The following is a description of a gene set: from publication Sansom OJ, Reed KR, Hayes AJ, Ireland H, Brinkmann H, Newton IP, Batlle E, Simon-Assmann P, Clevers H, Nathke IS, Clarke AR, Winton DJ (PMID 15198980) Although Apc is well characterized as a tumor-suppressor gene in the intestine, the precise mechanism of this suppression remains to be defined. Using a novel inducible Ahcre transgenic line in conjunction with a loxP-flanked Apc allele we, show that loss of Apc acutely activates Wnt signaling through the nuclear accumulation of beta-catenin. Coincidentally, it perturbs differentiation, migration, proliferation, and apoptosis, such that Apc-deficient cells maintain a crypt progenitor-like phenotype. Critically, for the first time we confirm a series of Wnt target molecules in an in vivo setting and also identify a series of new candidate targets within the same setting. studied in species Mus musculus Top genes up-regulated at day 5 of Cre-Lox induced APC knockout in the intestine. Mouse Gene Set: SANSOM_APC_TARGETS_UP, and this is the list of marker genes: Uri1, Aqp4, Zc3h8, Tnfrsf12a, Vmn1r42, Ephb3, Krt23, Trpc2, Hnrnpa1, Hunk, Zfp746, Cdca7, Nr2e3 (nuclear receptor subfamily 2, group E, member 3), Paics, Sgf29, Tlr7, Tmem131l, Msx1, Golga3 (golgin A3), Tubb2b, Hs3st1, Ang, Foxa3, Bcas2, Ung, Ets2, Ube2t, Tcof1, Ccnd2, Agr3, Tnfrsf19, Ints7, Zfp318, Npc1, Sox4, Ehf, Piwil2, Trib1, Psat1, Marcksl1, Ctps1, Acot1, Snapc2, Ccdc86, Cybrd1, Poli, Ergic1, Krt18, Hopx (HOP homeobox), Prdx2, Mcm3, Eif2s2, Tubb2a, Mad1l1, Ephb2, Chrnb4, Dtymk (NCBI Gene Id 98609), Impdh2 (inosine monophosphate dehydrogenase 2), Sox9, Mcm2, Lrig1, Diaph3, Gm20559, Tgfbr2, Emp2 (NCBI Gene Id 223964), Impa2, Mt4, Cited1, Msi1, Dyrk3, Sox17, Cd320, Mycl, Oxct2a, Kat2a, Zfp97, Axin2 (axin 2), Gnb1l, Shf, Hes6, Slc40a1, Wdfy1, Egr1, Rnase4, Tgif1, Psmg2, Cdc37, Snhg6, Sp5, Mcm6, Skp2, Car12, Rpp14, Zfp282, Epop, Rec8, Mcm7, Ggh (NCBI Gene Id 667301), Polr1has, Dlk1, Meg3, Recql (RecQ protein-like), Rgcc, Adat1, Kcnq1, Nectin4, Cpn1, Slc12a2, Qser1, Atl3, Slc1a4 (solute carrier family 1 (glutamate/neutral amino acid transporter), member 4), Pask, Txnrd3, Parp1, Paxip1, Abcc5, Tc2n, Dtl, Tnni1, Ect2, Ascl2, Tcf7, Cd44, Glul (glutamate-ammonia ligase), Rpl14, Zfp975, Rnf43, Gtf3c4, Acer2, Igfbp4, Tiam1, Mri1, Myl7 (myosin, light polypeptide 7, regulatory), Slc39a14